The following is a description of a gene set: studied in species Homo sapiens Human Gene Set: GOBP_TELOMERE_ORGANIZATION A process that is carried out at the cellular level which results in the assembly, arrangement of constituent parts, or disassembly of telomeres, terminal regions of a linear chromosome that include the telomeric DNA repeats and associated proteins., and this is the list of marker genes: BLM (NCBI Gene Id 641), PTGES3, ACD, SMC5, TERC, MAPKAPK5, RUVBL2 (NCBI Gene Id 10856), H4C9, ACTR8, PCNA, SMG1, LTO1, RUVBL1, PRKCQ, CTNNB1, H3-3B (H3.3 histone B), CCT4, HSP90AA1, H3C8, MAPK1, FBXO4, SHLD1, TCP1, H4C8, RAD51C, PARN, TFPT, TFIP11, TEP1, PARP3, H3C2, H4C16, NBN, NEK7, ATR, MYC, MAP3K4, TNKS1BP1, TERF1, H4C13, ZBTB48, H4C5 (H4 clustered histone 5), AURKB, SLX4, GNL3L, RAD51D, SLF1, PARP1, INO80B, STN1 (NCBI Gene Id 79991), EID3, YY1, BRCA2, CCT5, SLX1A, TP53, H3C1, RFC1, XRCC5, CCT6A, HSP90AB1, TINF2 (NCBI Gene Id 26277), ERCC1, RPA1 (NCBI Gene Id 6117), NVL, EME2, RAD51, ZNF827, NABP2, DHX36, MCRS1, PPP1R10, POT1, NSMCE3, PINX1, ATRX, HNRNPU, SRC, CDK2, NHP2, NSMCE2, XRCC6, RPA3, FEN1, H4C4, INO80D, DNA2, NSMCE1, XRCC3, NHEJ1, H4C12, INO80 (NCBI Gene Id 84156, INO80 complex ATPase subunit), SLF2, TNKS2, H4C3, LRRC34, RTEL1, NOP10, PNKP, H3C12, GNL3, SHLD2, MRE11, EXOSC10, H3C6, H3C7, XRCC1, CCT2, SIRT6, CTC1, WRN, TNKS, H4C1, PKIB, NEK2, HDAC8, H3C3, SPDYA, TEN1, CCT8, RIF1, DOT1L, SMC6, HNRNPD, ZNF365, YLPM1, PRKDC, WRAP53, LMNA (NCBI Gene Id 7816), ACTL6A, H4C2, MAP2K7, CCT7, H3C4, HNRNPA1, SMARCAL1, INO80E, KLF4, ACTR5, PML, MAPK3, RPA2, XRN1, EXO1, SLX1B, H3-3A, PIF1, DKC1, UCHL5, DCLRE1C, HUS1B, ZSCAN4, MAD2L2, DCP2, RAD50, INO80C (INO80 complex subunit C), HMBOX1, ATM, USP7, TERF2, TENT4B, H4C15, H4C6, H4C11, PPP1CA, H3C10 (NCBI Gene Id 8357), SMG5, SHLD3, CCNE2, UPF1, MAPK15, NFRKB, SMG6, RECQL4, H4C14, HUS1, ERCC4, TERF2IP, NSMCE4A, TERT, GAR1, DCLRE1B, NAT10, HNRNPC, APEX1, CCNE1, HNRNPA2B1, CCT3, NAF1, H3C11, SP100 (NCBI Gene Id 6672)